Given this list of marker genes DAZL, OTX1, PRM1, APOD, MDK, PIP5K1A, TFPI, ADAM28, here is a description of the gene set: Down-regulated genes in medulloblastoma tumors from heterozygotic CXCR6 knockout mice compared to those from PTCH1 heterozygotic knockout mice. studied in species Mus musculus Human Gene Set: SASAI_TARGETS_OF_CXCR6_AND_PTCH1_DN from publication Sasai K, Romer JT, Kimura H, Eberhart DE, Rice DS, Curran T (PMID 17413002) The sonic hedgehog (Shh) pathway is activated in approximately 30% of human medulloblastoma resulting in increased expression of downstream target genes. In about half of these cases, this has been shown to be a consequence of mutations in regulatory genes within the pathway, including Ptc1, Smo, and Sufu. However, for some tumors, no mutations have been detected in known pathway genes. This suggests that either mutations in other genes promote tumorigenesis or that epigenetic alterations increase pathway activity in these tumors. Here, we report that 3% to 4% of mice lacking either one or both functional copies of Cxcr6 develop medulloblastoma. Although CXCR6 is not known to be involved in Shh signaling, tumors derived from Cxcr6 mutant mice expressed Shh pathway target genes including Gli1, Gli2, Ptc2, and Sfrp1, indicating elevated pathway activity. Interestingly, the level of Ptc1 expression was decreased in tumor cells although two normal copies of Ptc1 were retained. This implies that reduced CXCR6 function leads to suppression of Ptc1 thereby increasing Smoothened function and promoting tumorigenesis. We used a direct transplant model to test the sensitivity of medulloblastoma arising in Cxcr6 mutant mice to a small-molecule inhibitor of Smoothened (HhAntag). We found that transplanted tumors were dramatically inhibited in mice treated for only 4 days with HhAntag. These findings suggest that HhAntag may be effective against tumors lacking mutations in known Shh pathway genes.